Given this list of marker genes ERF, LRP2, WT1, GNB2, MYCN (NCBI Gene Id 53360), POLR1A, ALDH1A2, PLOD3, IGHMBP2, MEGF10, DNAJC19, MYOD1, MTM1 (myotubularin 1), STRA6, TRIP4, REEP1, ZNF699, CHRNG, ASNS, MEGF8, ARID2, here is a description of the gene set: species: Homo sapiens Diaphragmatic eventration Human Gene Set: HP_DIAPHRAGMATIC_EVENTRATION A congenital failure of muscular development of part or all of one or both hemidiaphragms, resulting in superior displacement of abdominal viscera and altered lung development.